The following is a description of a gene set: Human Gene Set: HE_LIM_SUN_FETAL_LUNG_C0_PERICYTE Pericyte studied in species Homo sapiens from publication He P, Lim K, Sun D, Pett JP, Jeng Q, Polanski K, Dong Z, Bolt L, Richardson L, Mamanova L, Dabrowska M, Wilbrey-Clark A, Madissoon E, Tuong ZK, Dann E, Suo C, Goh I, Yoshida M, Nikolić MZ, Janes SM, He X, Barker RA, Teichmann SA, Marioni JC, Meyer KB, Rawlins EL (PMID 36493756), and this is the list of marker genes: EBF1, LRRC32, REM1, TNFRSF21 (TNF receptor superfamily member 21), CDH6, CXCR4 (C-X-C motif chemokine receptor 4, NCBI Gene Id 93405), GPR183, PLCB1, TRPV2, HOXB-AS1, ANKRD44, GRK3, COX4I2, CYTOR, MLLT3, HRH2, SMIM3, CDC42EP2, SPRY4, ADGRD1, GRP, CLIP1, CYGB (cytoglobin), MCAM, EPS8, TPPP3, NAB1, TRIB2, PDLIM5, ARID5A, EPAS1, MAP2, NEURL1B, HIGD1B, MGLL, MOCS1, RFTN1, ARHGAP42, CAMK1D, SLC35B3, TANC1, TES, PAWR, CYTH3, HSPA2, SH2D3C, TINAGL1, PDZD2, APLNR, FHL5, NOTCH3, ABCC9, IGFBP2, PERP, VSNL1, ADGRF5, OLFM2, MEF2C, ANGPT2, NECAB1 (N-terminal EF-hand calcium binding protein 1), GPX3, TRPC6, MTSS2, SRSF8, PRKCA, DBNDD2, PTEN, PAG1, C1QTNF5, OLFML2B, ARHGAP29, KIAA0040, STARD9, DYRK2, HES1, COL18A1, SEZ6L2, MYOF, NGFR, RAPGEF5, LRRC4B, ISG15, ADAMTSL3, PKNOX2, ARHGEF12, GJA4 (NCBI Gene Id 2701), SNRK, KCNK17, PLEKHH3, ENDOD1, GJC1, HES4, KLHL23, SH3KBP1, DUSP4 (NCBI Gene Id 1846), PDE3A, FKBP5 (NCBI Gene Id 2289), NBEA, GUCY1A2 (guanylate cyclase 1 soluble subunit alpha 2), TESC, LINGO1, INPP4B, GPM6B, RASD1, KITLG, CHRD, ETS1, HRC, NPR3, CSPG4, PLXDC1, DGKZ, COL5A3, ECE1, KCNJ8, DGKH, NRGN, MYO3A, CRISPLD2, KCNK3, MCTP2, SYTL2, SLC7A2, WFDC1, CYP4X1, HEYL, LIN7A, MASP1, GMFG, TMEM204, RERG (NCBI Gene Id 85004), RRAD, MIR4435-2HG, EGFLAM, VASP, BTBD3, SERPINI1, RPS6KA2, BCAS3, PLEKHA2, FOXS1, NDRG1 (NCBI Gene Id 7998), A1BG, ARHGDIB, PHLDB3, SEMA5B, CCDC3, RXRG, MAPT, ESAM, PPFIBP2, ADCY3, CCDC102B, DOCK6, MT1E, ALDH1A2, ITGA4, DMD, SEMA5A, DENND2A, PLEKHG3, PEAR1, IMPA2, P2RY14, KCP, SEMA6D, CAV2, HACD4, KLHDC8B, ARHGEF17, NCK2, ITPRIPL2, PCDH1, ABTB1, KCNS3, AGRN, CNTN4, NDUFA4L2, PLCE1, CYSTM1, RRAS2, ARHGAP26, RASL11A, MT1X, RCSD1, RGS5, AFAP1L2, GAS6, ADAMTS5, LAMC3, ADAMTS9, SEPTIN4, MTUS1 (NCBI Gene Id 57509), NTRK3, MARK1